Given this list of marker genes Cln8, Lhx3, Lhx4, Phox2a, Pax6, Tctn1, here is a description of the gene set: The process in which neuroepithelial cells in the neural tube acquire specialized structural and/or functional features of somatic motor neurons. Somatic motor neurons innervate skeletal muscle targets and are responsible for transmission of motor impulses from the brain to the periphery. Differentiation includes the processes involved in commitment of a cell to a specific fate. Mouse Gene Set: GOBP_SOMATIC_MOTOR_NEURON_DIFFERENTIATION studied in species Mus musculus